The following is a description of a gene set: DNA methylation is essential for normal development and has been implicated in many pathologies including cancer. Our knowledge about the genome-wide distribution of DNA methylation, how it changes during cellular differentiation and how it relates to histone methylation and other chromatin modifications in mammals remains limited. Here we report the generation and analysis of genome-scale DNA methylation profiles at nucleotide resolution in mammalian cells. Using high-throughput reduced representation bisulphite sequencing and single-molecule-based sequencing, we generated DNA methylation maps covering most CpG islands, and a representative sampling of conserved non-coding elements, transposons and other genomic features, for mouse embryonic stem cells, embryonic-stem-cell-derived and primary neural cells, and eight other primary tissues. Several key findings emerge from the data. First, DNA methylation patterns are better correlated with histone methylation patterns than with the underlying genome sequence context. Second, methylation of CpGs are dynamic epigenetic marks that undergo extensive changes during cellular differentiation, particularly in regulatory regions outside of core promoters. Third, analysis of embryonic-stem-cell-derived and primary cells reveals that 'weak' CpG islands associated with a specific set of developmentally regulated genes undergo aberrant hypermethylation during extended proliferation in vitro, in a pattern reminiscent of that reported in some primary tumours. More generally, the results establish reduced representation bisulphite sequencing as a powerful technology for epigenetic profiling of cell populations relevant to developmental biology, cancer and regenerative medicine. Genes with intermediate-CpG-density promoters (ICP) bearing histone trimethylation marks at K4 (H3K4me3) and K27 (H3K27me3)ES cells (embryonic stem). studied in species Mus musculus from publication Meissner A, Mikkelsen TS, Gu H, Wernig M, Hanna J, Sivachenko A, Zhang X, Bernstein BE, Nusbaum C, Jaffe DB, Gnirke A, Jaenisch R, Lander ES (PMID 18600261) Mouse Gene Set: MEISSNER_ES_ICP_WITH_H3K4ME3_AND_H3K27ME3, and this is the list of marker genes: Mogat1, Evpl, Lyl1, Ggt7, Prokr1, Tspan11, Coro1a, Tnfrsf13c, Epn3, Pak5, Foxs1, Cnmd, Tssk3, Adam33